Given this list of marker genes Trpm4, Rflnb, Hif1a, Ltbp3, Ccr1, Gata1, Ecm1, Mepe, Fgf23, Pth, Rflna, Bcor, Ahsg, Enpp1, Srgn, Grem1, Sox9, Ccr1l1, Nfe2, Ptk2b, here is a description of the gene set: species: Mus musculus Any process that stops, prevents, or reduces the frequency, rate or extent of bone mineralization. Mouse Gene Set: GOBP_NEGATIVE_REGULATION_OF_BONE_MINERALIZATION